Given this list of marker genes FRAT1, NRXN2, B3GNT8, FAM83F, LANCL3, DLGAP1, TGIF2, AUNIP, BASP1, MYO5C, HSD11B2, YBX2, KL, SHISA7, ANK1, MESP2, COL23A1, CD164L2, here is a description of the gene set: from publication Meissner A, Mikkelsen TS, Gu H, Wernig M, Hanna J, Sivachenko A, Zhang X, Bernstein BE, Nusbaum C, Jaffe DB, Gnirke A, Jaenisch R, Lander ES (PMID 18600261) Genes with high-CpG-density promoters (HCP) bearing histone H3 dimethylation mark (H3K4me2) in brain. Human Gene Set: MEISSNER_BRAIN_HCP_WITH_H3K4ME2 studied in species Mus musculus DNA methylation is essential for normal development and has been implicated in many pathologies including cancer. Our knowledge about the genome-wide distribution of DNA methylation, how it changes during cellular differentiation and how it relates to histone methylation and other chromatin modifications in mammals remains limited. Here we report the generation and analysis of genome-scale DNA methylation profiles at nucleotide resolution in mammalian cells. Using high-throughput reduced representation bisulphite sequencing and single-molecule-based sequencing, we generated DNA methylation maps covering most CpG islands, and a representative sampling of conserved non-coding elements, transposons and other genomic features, for mouse embryonic stem cells, embryonic-stem-cell-derived and primary neural cells, and eight other primary tissues. Several key findings emerge from the data. First, DNA methylation patterns are better correlated with histone methylation patterns than with the underlying genome sequence context. Second, methylation of CpGs are dynamic epigenetic marks that undergo extensive changes during cellular differentiation, particularly in regulatory regions outside of core promoters. Third, analysis of embryonic-stem-cell-derived and primary cells reveals that 'weak' CpG islands associated with a specific set of developmentally regulated genes undergo aberrant hypermethylation during extended proliferation in vitro, in a pattern reminiscent of that reported in some primary tumours. More generally, the results establish reduced representation bisulphite sequencing as a powerful technology for epigenetic profiling of cell populations relevant to developmental biology, cancer and regenerative medicine.